The following is a description of a gene set: species: Mus musculus Mouse Gene Set: GOBP_REACTIVE_OXYGEN_SPECIES_METABOLIC_PROCESS The chemical reactions and pathways involving a reactive oxygen species, any molecules or ions formed by the incomplete one-electron reduction of oxygen. They contribute to the microbicidal activity of phagocytes, regulation of signal transduction and gene expression, and the oxidative damage to biopolymers., and this is the list of marker genes: Slc25a33, Txn1, App, Nox4, Gnai2, Sirt5, Cyb5r4, Nos3, Grb2, Tspo, Eif5a, Ndufs4, Tgfb1, Sod1, Cyp1a2, Bcr, Duox2, Ncf4, Hbb-bh0, Pon3, Itgam, Rac2, Ucp1, Txnrd1, Pid1, Itgb2l, Clec7a, Trim30a, Pdgfb, Inava, F2, Ngfr, Hdac4, Norad, Tnf, Snca, Noxo1, Birc2, Blvra, Tyrobp, Ogt, Mfsd8, Sirt2, Mb, Ager, Cycs, Hk2, Rab27a, Fancc, Hbq1a, Brca1, Eif6, Lcn2, Prdx1, Foxo1, Ripk3, Naglu, Cysltr1, Hbb-bt, Hif1a, Stat3, Fyn, Snord34, G6pdx, Acod1, mt-Nd2 (mitochondrially encoded NADH dehydrogenase 2), Tlr6, Immp2l, Snord32a, Prdx6b, Tpo, Ncf2, Foxo3, Ucp2, Atp7a, Atp5if1, Insr (NCBI Gene Id 319666), Clcn3, Cryab, Coq7, Il4, Abcc1, Letmd1, Akr1c18, Hbp1, Dmd, Gbf1 (golgi-specific brefeldin A-resistance factor 1), Mpv17, Adgrb1, Bnip3, Tlr4, Ndufs6, Sirt1, Thbs1, Nqo2, Il22, Ptger4, Ndufs3, Hnf4aos, Vdac1, Prdx5 (NCBI Gene Id 54683), Prdx4, Ins1 (NCBI Gene Id 16333), Cyba, Sh3pxd2b (SH3 and PX domains 2B), Duoxa2 (NCBI Gene Id 66811), Xdh, Park7, Ripk1, Trp53, Hvcn1, Adcy10, Acox1, Edn1, Sod3, Gpx1, Snord33 (NCBI Gene Id 27208), Ctns, Lep, Duox1, Tgfbr2, Ndufc2, Birc3, Prdx2, Agtr1a, G6pd2, Pdgfrb, Prkcd, Pdk4, Fpr2, Cygb, Sod2, Hspd1, Ndufs1, Lrrk2, Pax2, Fam210b, Map3k7, Elavl1, Hbb-bh2, Mpv17l, P2rx7, Ins2, Prdx6, Lipa, Cdkn1a, Mycn, Tigar, Akt1, Nnt, Ptgr1, Grin1, Snord35a, Mmp3, Sesn1, Aldh2, Dcxr, Atg5, Hbb-bh1, Nfe2l2, Abcb7, Tafa4, Prcp, Sirt3, Mapk14, Met, Gadd45a, Ndufa13, F2rl1, Alox5, Syk, Plcg2 (NCBI Gene Id 234779), Fbln5, Nqo1, Alox12, Il18, Hbq1b (NCBI Gene Id 544763), Gnai3, Hbb-bs, Dhfr, Pmaip1, Ccn1 (NCBI Gene Id 99596), Cyp1a1 (cytochrome P450, family 1, subfamily a, polypeptide 1), Apoa4, Agt (NCBI Gene Id 11606), Duoxa1, Pikfyve, Noxa1, Cbs, Gch1, Mapt, Ppara, Coa8, Hba-a1, Crp, Vav1, Acp5, Bco2, Nrros, Ahr, Cyp1b1, Nos2, Rnf41, Egfr, Foxm1, Sphk2, Ptk2b, Bcl2, Mt3 (NCBI Gene Id 17751), Il19, Slc5a3, Ncf1, Pdk3, Cd177, Rhoa, Abcd1, Col6a1, Cxcl1, Mpo, Ccn2, Cd36, Cybb, Slc1a1, Epx (NCBI Gene Id 13861), Gstp1, Sh3pxd2a, Itgb2, Ddit4, Cyct, Tfap2a, Ccn6, Cat, Drd5, Prdx3, Abcd2, Rfk, Abcc9, Nox1, Cflar, Plin5, Parl, Zfp13, Ccs, Plau, Cbr1, Pxdn, Zc3h12a, Ier3, Hba-x, Pink1, Prkn, Gpx3, Sesn2, Mfn2, Esr2, Prex1, Gls2, Arf4, Shc1, Hbb-y (hemoglobin Y, beta-like embryonic chain), Nox3, Arg2, Prg3, Pla2r1, Cbr1b, Tusc2, Romo1